Given this list of marker genes SLC16A7, CDH11 (NCBI Gene Id 1009), CDA, FOXN3, PMCH, MCC, ST6GALNAC1, SULF2, SMPD1, SEMA3F, here is a description of the gene set: Human Gene Set: MCCOLLUM_GELDANAMYCIN_RESISTANCE_UP Genes up-regulated in A549GARS cells (lung cancer) resistant to the geldanamycin and 17-AAG. from publication McCollum AK, TenEyck CJ, Stensgard B, Morlan BW, Ballman KV, Jenkins RB, Toft DO, Erlichman C (PMID 18794130) studied in species Homo sapiens Despite studies that show the antitumor activity of Hsp90 inhibitors, such as geldanamycin (GA) and its derivative 17-allylamino-demethoxygeldanamycin (17-AAG), recent reports indicate that these inhibitors lack significant single-agent clinical activity. Resistance to Hsp90 inhibitors has been previously linked to expression of P-glycoprotein (P-gp) and the multidrug resistant (MDR) phenotype. However, the stress response induced by GA treatment can also cause resistance to Hsp90-targeted therapy. Therefore, we chose to further investigate the relative importance of P-gp and the stress response in 17-AAG resistance. Colony-forming assays revealed that high expression of P-gp could increase the 17-AAG IC(50) 6-fold in cells transfected with P-gp compared with parent cells. A549 cells selected for resistance to GA overexpressed P-gp, but verapamil did not reverse the resistance. These cells also overexpressed Hsp27, and Hsp70 was induced with 17-AAG treatment. When the GA and 17-AAG resistant cells were transfected with Hsp27 and/or Hsp70 small interfering RNA (siRNA), the 17-AAG IC(50) decreased 10-fold compared with control transfected cells. Transfection with siRNA directed against Hsp27, Hsp70, or Hsp27 and Hsp70 also increased sensitivity to EC78, a purine scaffold-based Hsp90 inhibitor that is not a P-gp substrate. We conclude that P-gp may contribute, in part, to resistance to 17-AAG, but induction of stress response proteins, such as Hsp27 and Hsp70, by Hsp90-targeted therapy plays a larger role. Taken together, our results indicate that targeting of Hsp27 and Hsp70 should be exploited to increase the clinical efficacy of Hsp90-directed therapy.